The following is a description of a gene set: Genes containing one or more binding sites for (KAT2A) in their promoter regions (TSS -1000,+100 bp) as identified by GTRD version 20.06 ChIP-seq harmonization. from publication Yevshin I, Sharipov R, Kolmykov S, Kondrakhin Y, Kolpakov F (PMID 30445619) species: Homo sapiens Human Gene Set: KAT2A_TARGET_GENES, and this is the list of marker genes: STARD7, MCU, DFFA, ZBTB37, DPP8, NDUFAF3, MRPS16, RNU4ATAC, RPS20, H2BC21, CARS2, LINC00663, ALDH7A1, TSC1, MIR3181, ABHD16A, ERVK3-1, BCAT2, CDC42EP4, TRAM2, AGK-DT, MRPS7, ZFAND3, FBXO31, SERPINI1, NMT1, TM2D1 (NCBI Gene Id 83941), ALG10B, CUL9, ITFG1, TMEM200B, PARGP1, DDX47, LINC01547, POLD3, TRIP12, ARF6, NFAT5, DDX39B-AS1, RPS26, TMEM259, LINC00869, MTERF4, SNHG3, WAC-AS1, ZNF219, TSPAN10, HAUS6, GPANK1, PCLAF, PET117, RPL3, ZNFX1, CTNNB1, PRR34, HIF1AN, NFATC3, CDC27, FANCI, LZTR1, ALAS1, CIPC, MAP4K1, COQ8B, NDUFC2-KCTD14, RBM48, MRPS12, AGPAT2, CCND1, RPL29, LYSMD1, RPP14, MOB1A, DCTN6-DT, ZNF862, HEBP2, ALOXE3, STAP2, SNX16, ARMC6, AMBRA1, POLDIP2, MIR191, ATXN2L, HP1BP3, ERRFI1-DT, RPL7A, PRMT5, SNORD58B, RPS17, MCM3AP, ZMYM4, MRPL18 (NCBI Gene Id 96273), PROSER1, EIF3K, RNU5B-1, MRPL21, DCTN6, DNAAF8, SEPTIN7-DT, SERTAD2, PGLS, RPS15, SCAF1, SLC25A25, NDUFC2, CRBN, TEX38, SH3GL1, RPA2, SH3YL1, DARS2 (aspartyl-tRNA synthetase 2, mitochondrial), PSMC2, PPP2CB, ANKRD24, FAM98B, TIMM23, PPP1R12B, HTD2, SMARCC2, CSNK1D, TRMU, LINC02918, ENPP3, NOP14, SPCS1, TMEM147, MMAB, C1orf43, PDE4D, NUDT22, PTGES3, SSNA1, JMJD4, UBE2I, CPSF1, MRPS28, WBP4, CHTOP, SNORD101, UHMK1, DTWD1, CDC45, RPS12, POLG-DT, CENPS, GTF3C5, RPS2, CTNNA1-AS1, AP4M1, PDCD10, PSMB6, ZFAND3-DT, ABT1, TCEA2, TMEM11, AURKAIP1, SNX27, CCT7, TXN2, GATB, PABPN1, RNASEH1, FBXW11, GAS5, LINC02960, NUMB, DHX8, C17orf75, MED18, XNDC1N, FBF1, AAGAB, GTF3C2-AS2, ZFTRAF1, GCDH, UBAP2L, RAD1, TXNDC9, DDX46, DPH6-DT, MAX, DNAJC17, USP24 (ubiquitin specific peptidase 24, NCBI Gene Id 388634), CSRNP2, PEMT, ARHGEF1, MKRN3, MIR3677HG, H4C2, ABHD5, KIFBP, FKTN-AS1, SEC13, BRD3OS, RNU6-999P, BAG5 (BAG cochaperone 5), ARPC5L, AGPS, AUNIP, TLCD3B, ZNHIT6, ZFAS1, DCAKD, TAFAZZIN, METTL15, COPS2, COA8, TAMM41, RANBP1, TNFAIP1, CALM1, WDR25, COMMD2, ZFX-AS1, CWC27, KBTBD7, MCEE, IER3, RNVU1-22 (NCBI Gene Id 106481627), CLUH, RNASE11, AKAP8L, PRRT3-AS1, CYP51A1-AS1, PHRF1, DCAF8, CNOT11, EEF2, RCE1, PPP2R2A, TXNDC11, CCDC6, TEDC1, ENDOV, ARK2N, HLA-DMA, MAIP1, MIR4530, RPL34-DT, NEURL4, CALR3, SNORA13 (NCBI Gene Id 654322), IER3-AS1, RNF187, SF1-DT, ADNP, RPL5, TONSL, EIF2B1, WDR27, SOX6, TSSC4, PARG, TMEM147-AS1, RNVU1-6, MRTO4, ZNF76, NCBP3, FAM200C, INTS12, PSMD12, CROCCP2, CDCA3, CDK8, GPN3, VPS13B, IQCH, CTNNBL1, LINC01556, TRIM41, IQCK (IQ motif containing K), GLO1, SNAP29, RBM26-AS1, BMS1, FUS, CLCN7, DLAT, PCYT1A, FAF1, ZCCHC8, SLC35G1, C16orf95, MTIF2, SIRT6, SRRT, KITLG, TRIP11, TRPT1, DPH6, UTP25, CHCHD7, DICER1, MTOR, MTF2, MED23, GFI1B, C19orf48P, CLPB, LINC01347, TPP2, EPB41L4A-AS1, NAA38, NSUN2, RNU5D-1, CELSR3, GAA, AHCYL2, GFM2, KCTD9, RCC1, CCDC97, DDX39B, TUBE1, PKMYT1, H4C1, TMTC3, CAP1, AGO3, C11orf68, CPSF2, EHD1, ABHD2, HJV, ENAH, KRR1, GCN1, LRRC14, GABPB1 (GA binding protein transcription factor subunit beta 1), FBXO36, CCNG2, TIGD1, WDPCP (WD repeat containing planar cell polarity effector), MCM7, B4GALT7, SNORD3A, MRPL36, POLR2I, AAAS, HSPA12A, BSG-AS1, H3-3B, MDH1, BSG, PEX2 (NCBI Gene Id 5828), ZNF445, IER5, UGGT1, LDHA, CYB5D1, ADAP2, CCDC163, TUBGCP3, MED15, VPS9D1, SERP1, E2F6, RPA3, SREK1IP1, KAT14, GCC2-AS1, SMG8, LBHD1, H4C8, SNORD15A, UBE2J1, SNRPD3, RNF135, KIFC2, NIF3L1, PPP5C, FKTN, LINC02585, BHLHE40-AS1, MALAT1, SENP5, EPB41L3, MSL2, DHFR, KCTD21-AS1, PPIL3, WAC, POLA1, PANK4, ELAC1, TTI2, ITGB3BP, TTC13, WARS1, ILF2, UQCC6, VCPIP1, PKM, RNF220, SZRD1, ELF1, BORCS8, TOR1AIP1, GGA3, SMAD5, ANTKMT (adenine nucleotide translocase lysine methyltransferase), ELP3, GSPT1, SNHG32 (NCBI Gene Id 50854), LINC01970, LINC02086, SNORA78, RNF216, MARVELD1, THADA, SLX9, CALCOCO1, GTF2H3, TAF5, SLC27A5, KMT5B, ATP5MF-PTCD1, RPL6, SIL1, EIF4A2, NELFB, EIF4E2, PLEKHA8, NTAN1, DCP1A, ESYT1, TBC1D8, MKRN2, PABPC1, JUNB, COX19, ARL3, ZNF341-AS1, TXNRD2, ZBTB21, NDUFS3, RPL17-C18orf32, VEGFA, HSPA1B, CEP192-DT, STK17A, NEK4, PPP4R3A, USP39, DUS1L, ICMT-DT, CLTC, NDUFA3, RPL31, SMARCD2, ZFP91-CNTF, RPL39, KMT2A, GABPB1-AS1, MED22, UNK, CYCS, PLAG1, EIF1B-AS1, H2BC5, RPL35, ZC3H15, ZNF367, ZBTB45, GNAS, TACO1, HRAS, NEAT1, MAN1A2, C14orf93, KATNBL1, EIF2D, TDRD3, HNRNPA0, BRD2, CIAO3, TRIM7-AS2, NDUFS7, HNRNPDL, ABHD10, ZNF56P, EXOSC3, SLC35F5, DNAAF5, ADAM17, ZBTB5, RNVU1-14, MANBAL, RANGAP1, GTPBP3, GLT8D1, VEZF1, GOT2, PRKAB2, ZER1, ELOA-AS1, AARS2, TBC1D23, GOLM2, FIZ1, ALDOA, IL4I1 (NCBI Gene Id 259307), PRMT5-DT, TMEM198B, SNAP47, FAAP100 (NCBI Gene Id 80233), TRABD, LSG1, EED, TRAP1, ANKS3, UQCC4, SF1, CDC123, CYP51A1, WRAP53, SARS2, RNU5E-4P, UBQLN4, HNRNPUL1, ATF5, CENPL, RALBP1, RNVU1-30, MVK, NFE2L2, EFCAB7, SUPT5H, PDCD6IP, SNX12, PIGL, TPI1P2, SNORD118, SF3B4, SOX2-OT, CEP290, CFAP418, LIPT2-AS1, CLDN7 (NCBI Gene Id 1366), TUBA1C (tubulin alpha 1c), GDI1, FBXO45, SLC4A2, TTC4, SNORD95, PGLS-DT, NUP107, H2BC7, LIAS, TMEM11-DT, IFT88, EVI5L, FBXO22, ZNF581, CUL4A, WDR53, IFT20, RSAD1, SNORD54, ADPRS, FBXL19-AS1, FAM168A, ANAPC5, CLEC16A, RWDD1, RBL1, CEP192, PFN2, FLII, PLXDC1, ALG8, MDM4, TIMM21, LIMS1, ZMPSTE24, ARID4B, PRPSAP1, ACTG1, MMACHC, SNX1, GRK4, TIMM23B, PHAF1, GALE, FEM1A, XPC, VAMP4, RBM28, ZNF691-DT, DNAJB4, TAF6, CGB2, SRD5A1, LAMTOR5-AS1, N4BP3, H4C4, ZC3HAV1L, RPL34 (NCBI Gene Id 6164), MAPKAPK5, ACP1, RNASEH1-DT, KNL1, BOD1, MARK4, VPS28, ZNF691, C19orf44, ORMDL3, ZNF337, PHKB, IPO4, TBCB, NUDT9, KNOP1 (lysine rich nucleolar protein 1), ZNF524, NCOA7, NUDCD1, RPL38, ZBTB1, HSP90AA1, RNF216P1, WNK1 (WNK lysine deficient protein kinase 1), NOP58, CYB5D2, HNRNPAB, METTL25, VAMP8, BRF2, MIR31HG, DNAJC19, CCDC57, RPL41, DNAJC2, ST3GAL2, CNOT4, TOP3B, CSNK2B, DSTYK, DNAJA1, B4GAT1-DT, LRP3, BNIP1, MIR548AW, RNU5E-1, DALRD3, GDI2, SNORD43 (NCBI Gene Id 26807), TSN, EIF4A1, RPL9, CCDC174, NDC1 (NDC1 transmembrane nucleoporin), CENPBD2P, PSMD4, MRPS33, ZNF224, THOC6, PEX3, ERCC5, RNU5F-1, VTRNA1-2, ZBTB25, LINC03057, RPL8, SF3A3, TK1, UBE3A, RNVU1-4, C1orf159, RBBP5, GUSB, GEMIN7, TMED10, ZNF276, SIVA1, STRIP1, LZIC, KDM5C, CAB39, RNU7-1, CDK5RAP2, SMG7-AS1, TSEN15 (NCBI Gene Id 92120), USP21, GABARAP, RNY1, FAM229B, RNU12, PCAT6, DRAM2, CCDC59, DDX1, SUGP2, PRORP, HCG14, DDX23, GGA1, CDC7, FAM216A, PBRM1, GTF2I, CEP95, CHMP4B (NCBI Gene Id 60501), TCP1, MIPEPP3, ZFYVE1, NHLRC2, MIR1302-3, THRAP3, HEXA-AS1, CHD8, SPRED1, VPS13B-DT, SS18L2, ZMPSTE24-DT, ZNF767P, CNPY4, CYLD, SFPQ, MIDN, VTI1A, OTUD7B, SOD1-DT, HGH1, DNAJC14, ITFG2-AS1, DDX6, GGPS1, ACP2, MARCKSL1P2, IFTAP, WRNIP1, RPL18, METTL9, RIC8B, GNL3, RAD52, CCPG1, GTF2H4, RNU4-2, C8orf82, PPRC1, ERF, ZNF143, PLK1, EMC1, RANBP10, NUP107-DT, B4GAT1, CDK4, AAR2, RNA5SP283, STAU1, ZMAT2, AFF4, CLPTM1L, OSCAR, UCK1, MRFAP1L1, EMC3, BORCS8-MEF2B, NVL, SCNM1, RNVU1-27, PGS1, GCFC2, SCAF8, HUS1, NHLRC3, ERAL1, SNX8, TIMM44, HSPD1, ATP1A1-AS1, MATR3, LAMTOR2, SKP1, NDUFAF4P1, MNAT1, MIR4638, SNORD13, BLOC1S6, TNPO2, POLR2A, FOXK2 (NCBI Gene Id 84213), STAT3, TMEM69, SNX19, ALG10, ATPAF1 (NCBI Gene Id 64756), EIF4ENIF1, ACSF3, LAMTOR5, VPS72, PPP1R12C, DCAF7, SFXN2, H2AC20, SNHG9, TMSB10, UPF1, TMA16, MED4, GHET1, AFF4-DT, DDX5, PPP1CC, TRIM33, ENSG00000277020, LINC00467, EIF4G3, PCID2, ZFY, AFMID, CCDC88A, DHX9, FMO5, MADCAM1, RNF121, MRFAP1, MAGOHB, PPP2R5B, ICMT, SYPL1, API5, ID2-AS1, TRMT2A, ISG20L2, PIGQ, HSPE1, TRIM7, MRPS27, SF3B6, RNF213-AS1, CCDC47 (coiled-coil domain containing 47), RNU2-63P, DNAJC11, DPY19L4, ZNF165, NAIF1, NOP56, CASP7, SNRNP27, HSPA6, ID2, JMJD1C, NMNAT1, ZC3H6, DNM1, KRT36, UQCC3 (ubiquinol-cytochrome c reductase complex assembly factor 3), DRAP1, FAM228B, SNORD24, DICER1-AS1, CRTC2, RNU6-1, SF3B5, UBTF, PTCD1, MLEC, HNRNPLL, LINC03072, TNPO3 (NCBI Gene Id 404679), IGHMBP2, KBTBD4, METTL25B, C12orf57, YBX1, NFYB, RNASE4, RNH1, CCNL1, SEPTIN9, HEXA, TYW5, RRP7A (ribosomal RNA processing 7 homolog A), NDUFB1 (NCBI Gene Id 4707, NADH:ubiquinone oxidoreductase subunit B1), NDUFA12, RPL13A, TRERF1, ZMYND11, NSA2, LPGAT1, CCDC80, MAP3K3 (NCBI Gene Id 4215), SEC22C, MIR4674 (NCBI Gene Id 100616301), CCNJ, ENSG00000213963, SLC44A1, RPS16, TTC33, FBXO15, DCLRE1A, ARV1, MRPL39, EIF3E, FBXL19, PHIP, HSP90B1, CDKN2C, SNHG17, BOD1L1, CHSY1, RNPS1, HASPIN, VANGL2, A2M-AS1 (NCBI Gene Id 144571), CTNNA1, ZBTB4, SLC22A31, BRIX1, GALK2, LINC01623, TEX10, HNRNPH3, ADAT2, FAM227B, CYB561, ATAD2, SCARNA2, NUP85, LRPAP1, KRCC1, RFXANK, CHERP, UFD1, SNORD84, CERNA3, ANG, SLC15A4, PIM3, ZDHHC6, TEFM, GSTCD, SNORD12C, LITATS1, TCF3, HDGFL2, SEPTIN7, PRKDC, UBAC2, IFRD2, RNU7-27P, SLC9A1, GGCX, HMGA2, CEP20, PARP4, RETSAT, MCL1, CDK5, NDUFS6, CIAO2A, DNAJB6, CLASP1, ENY2, HSD11B2, HCFC1R1, ZNF195, UBR2, MRPL48, ZNF839, MPHOSPH10, INTS5, FLOT1, MIB2, TLNRD1, YTHDF1, MBTPS2, TBC1D31, SBNO2 (NCBI Gene Id 22904), AGK, VMP1, C11orf58, POLDIP3 (DNA polymerase delta interacting protein 3), PEX1, MRPL17, DVL3, MAPKAPK5-AS1, MIR5087, RPS13, WDFY1, LASP1, MIR4734, RNU5A-1, CRLS1, ZZEF1, MCOLN1 (NCBI Gene Id 57192), PARP2, SLC11A2, E2F3, PDIA4, RACK1, FGD5-AS1, HMGN1, CENPS-CORT, MADCAM1-AS1, ITGAE, RPS4X, MELTF-AS1, NOTCH1, MKS1, PCBP2, EMC3-AS1, NCKIPSD, MAP1LC3B, MIR1538, RNU6-2, NR2C2, TBC1D30, EPCAM, PDS5A, PHF12, USP30, SMG7, ADPGK, PITHD1, GPBP1L1, PUM2, ZNF3, LIPT2, REXO1, TMEM242, PPP2R3C, HSPE1-MOB4, BOLA1, S100PBP, SLC35A3, MRPL19, ANAPC2, DHDDS, EIF3B (NCBI Gene Id 8662), LINC01962, ZC3H10, ATP5MF, EIF4E, TMEM242-DT, NOP16, NHERF1, EIF5B, SCRIB, SDC4, PIPOX, VARS2, MORF4L1, DNAH7, SNORD48, GUCD1, EIF1B, ENTPD1-AS1, UBAC2-AS1, TMEM199, CIZ1, MCM4, ATP2B1, IMP3, C6orf120, RNU4-1, MSH3, TTC41P, ZNF143-AS1, LARS1, EIF3D, THA1P, TRAM2-AS1 (TRAM2 antisense RNA 1 (head to head)), RPS7, YBEY, FBXO5, FKBP15, TUBB, CDCA2, ZFYVE19, C16orf95-DT, NLRX1, RPIA, NSFL1C, RPL36, ERRFI1, NDUFV3, MCM8-AS1, SNRPB, AXL, RNVU1-28, PGBD2, ZNF706, POLR3E (RNA polymerase III subunit E), LPGAT1-AS1, IPO13, CBX3P2, NUDT5, BCAR3, NR1H3, ATXN10, ARID1A (NCBI Gene Id 8289), IQCG, PAQR4, GORASP2, SECISBP2, H2AC7, SUPV3L1, KAT6A, ZFP91, ZC3H12A, COPS3, MST1P2, STMP1, TRIP4, MCMBP, RPL35A (ribosomal protein L35a), BBS1, ZNF770, SNORA48, RNVU1-3, POLG, PIAS4, AKIRIN2, PDIA5, RPL17, C12orf76, YARS1, B3GALT4 (NCBI Gene Id 87866), HMGN4, LPXN, SLC31A1, ANO10, MTCH1, PIERCE2, GRPEL2, SRI, GTF3C2, TIPIN, PPP1R8, SPHK2, UCKL1, TMED2, LINC01719, PHB1, CEPT1 (NCBI Gene Id 10390), PHF3, RNVU1-15, MRPL38, TSNAXIP1, RBM26, NPLOC4, GBA1, MIR5091, RPS3, MTMR9, APTX, ZNF37A, ABCF2, PI4KA, MAZ, NUP62, FAM222B, COMT, KCTD5, UBB, TOMM7, ELMOD3, SLC38A10 (solute carrier family 38 member 10)